Given this list of marker genes FLYWCH1, FEZF2, DENND6A, GGT5, GAS6, SCN3B, FMO2, SPATS2L, DDR2 (NCBI Gene Id 4921), ACTR5, FOLR2, ZDHHC11, WNK1, OMG, RNASEL, HGSNAT, IL15, RBM15 (NCBI Gene Id 64783), DMXL1, SARAF, SPAG8, CCL8, SEC62, NQO1, CDC42BPA, HNRNPH3, SELENOM, ATP6V0A1, TRAPPC6B, RND1, RPP40, MTMR10, GSTT2, IGFLR1, RIPK1, HS2ST1, LGI2, NPC1, LENG9, ATP13A4, HSD17B2, SQOR, OXT, TCEAL1, WNT8A, POLG, PCOLCE2, DSE, MYL9, ADIPOR1, CP, BSDC1, EPO, TRIM56, PLEKHG5, CFH, TMEM30A, RNF17 (NCBI Gene Id 56163), RAB33B, SNAP23, TRIM10, KLF3, SIRT6, MGST3, INPP5A, P2RX7, LDAF1, VSIG4, SHE, FAM216B, ANXA8, TMEM51, DCAF12L2, SAA3P, NECTIN3, SLC16A10, SPTLC2, GPX3, PEG10, CMAHP, RAPGEF5, CALCRL, STXBP6, PAM, NDUFS7, SLC2A8, SP6, CXCL13, TBC1D2B, TMEM63B, ARAP3, CREB3L4, EDNRB, XDH, IL13RA1, FKBP9, LIX1L, REG4, ATP6AP1, IKBKE, CLPX, MIR340, PCDHB16, ITGA6, RDM1, RTN4, ACBD7, MGP, ETV4, ST6GALNAC6, KRT8, SUSD1, PERP, PRR15L (proline rich 15 like), PABPC1L, CABLES1, IL17A, NPTN, FOXN3, SLC25A51, NUCB1, LAMC1, ZCCHC14, SHMT1, SLC30A10, ADO, SLC6A4, FRMD6 (FERM domain containing 6), ZCCHC3, FAM114A1, NID1, ATP10B, CTU2, XPOT, VAMP3, GFOD2, CD38, CDR2, CBLL1, IGF2BP3, CCKBR, GPA33, MKX, PSENEN, CRYBA4, MAP1LC3A, GRXCR1, MAGEB3, ADAMTS6, GTSF1L, PPM1E, CDH6, SYT13, TMEM117, SPIN2A, here is a description of the gene set: studied in species Homo sapiens from publication Dudziak D, Kamphorst AO, Heidkamp GF, Buchholz VR, Trumpfheller C, Yamazaki S, Cheong C, Liu K, Lee HW, Park CG, Steinman RM, Nussenzweig MC (PMID 17204652) Genes up-regulated in splenic dendritic cells versus 33D1+ B lymphocytes. Human Gene Set: GSE6259_33D1_POS_DC_VS_BCELL_UP Dendritic cells (DCs) process and present self and foreign antigens to induce tolerance or immunity. In vitro models suggest that induction of immunity is controlled by regulating the presentation of antigen, but little is known about how DCs control antigen presentation in vivo. To examine antigen processing and presentation in vivo we specifically targeted antigens to the two major subsets of DCs using chimeric monoclonal antibodies. Unlike CD8+ DCs that express the cell surface protein CD205, CD8- DCs, which are positive for the 33D1 antigen, are specialized for presentation on MHC class II. This difference in antigen processing is intrinsic to the DC subsets and associated with increased expression of proteins associated with MHC processing.